Given this list of marker genes Ifi214 (interferon activated gene 214), Net1, Ints7, Lig4, Sfrp1, Rnf8, Rhob, Ddias, Mndal, Ect2, Usp28, Tigar, Pmaip1, Snai2, Yap1, Tlk2, Ints3, Brcc3, Map3k20, Paxip1 (PAX interacting (with transcription-activation domain) protein 1), Ifi206, Itgb6, Elk1, Nipbl, Rnf4, Ifi203, Myc, Kdm4d, Gpx1, Cdkn1a, Zmpste24, Rad9a, Kat5, Mta1, Nucks1, Brcc3dc, Mdm2, Trp53, Ptprc, Clk2, Xrcc2, Mrnip, Hras, Gtf2h5, Trp53bp2 (NCBI Gene Id 98424), Dnmt3a, Cxcl2, Dclre1c, Chek2, Xrra1, Abcg5, Men1, Cdkn2a, Prkdc, Casp3, Tmem109, Trp53bp1 (NCBI Gene Id 27223), Nabp2, Pnp, Ifi209, Lrp2, Xrcc5, Bcl2, Ticrr (TOPBP1-interacting checkpoint and replication regulator), Cop1, Ccl2, Rad9b, Hsf1, Bax, Ino80, Cbl (NCBI Gene Id 12402), Il1a, Rad51, Rnf168, Aen, D7Ertd443e, Tnf, Rfwd3, Ccnd2, Star, Lcn10, Grb2, Dcun1d3, Eya1, Wrn, Rrm1, Nabp1, Smpd1, Kdm1a, Gadd45a, Egr1, Bbc3, Prkaa1, Xrcc4, Msh2, Trex1, Rpl26, Sfrp2, Fbxo4, Inip, Ifi203-ps, Bmyc, Nhej1, Eef1d, Cyp2r1, Brat1, H2ax, Kars1, Bard1, Polb, Ercc1, Swi5, Ercc8, Ifi213, Babam2, Bcl2l1, Mecp2, Cryab, Nek1, Gata3 (NCBI Gene Id 14462), Rad54l, Fignl1, Atr, Apobec1, Rad54b, Eya3 (EYA transcriptional coactivator and phosphatase 3), H2aj, Rad51ap1, Tnks1bp1, Bak1, Tank, Rad1, Abraxas1, Mapk14, Topbp1, Blm, Pml, Babam1, Ifi208, Sod2, Alad, Ccl7, Fancd2, Spidr, Ercc6, Tgfb1, Ifi207, Atm, Hus1, Prap1, Brca2, Uimc1, Clock, Tspyl5, Brca1, Stk11, Xrcc6, Thbd, Rhno1, Sirt1, here is a description of the gene set: studied in species Mus musculus Mouse Gene Set: GOBP_RESPONSE_TO_IONIZING_RADIATION Any process that results in a change in state or activity of a cell or an organism (in terms of movement, secretion, enzyme production, gene expression, etc.) as a result of a ionizing radiation stimulus. Ionizing radiation is radiation with sufficient energy to remove electrons from atoms and may arise from spontaneous decay of unstable isotopes, resulting in alpha and beta particles and gamma rays. Ionizing radiation also includes X-rays.